Given this list of marker genes PLEC, ENPP1, NONO, KRT14, SPECC1L, TSC2, CDKN1B (cyclin dependent kinase inhibitor 1B), CDKN1A, CDKN2C, EPHB4, MEN1, GPNMB, DNAJC21, PSENEN, IFNG (interferon gamma), RASA1, NF1, TSC1, CDKN2B, FANCC, ANKLE2 (NCBI Gene Id 23141), ABCB6, KRT5, SASH1, POGLUT1, POFUT1, here is a description of the gene set: species: Homo sapiens A white or lighter patch of skin that may appear anywhere on the body and are caused by decreased skin pigmentation. Human Gene Set: HP_HYPOPIGMENTED_MACULE Hypopigmented macule